Given this list of marker genes EDEM2, RNF185, UBA52, UBB, CANX, MARCHF6, RNF139, DERL2, RNF103, SEL1L, UGGT1, RPS27A, UGGT2, EDEM1, GANAB, PDIA3, UBC, RNF5, EDEM3, OS9, TRIM13, AMFR, MAN1B1, CALR, SYVN1, PRKCSH, here is a description of the gene set: Calnexin/calreticulin cycle species: Homo sapiens Human Gene Set: REACTOME_CALNEXIN_CALRETICULIN_CYCLE